Given this list of marker genes GRB2, FLT3LG, TLR9, FGF5, GAB2, IRS2 (insulin receptor substrate 2), FGFR2, FGF22, FGF4, PIK3R4, KRAS, FGF10, FGF23, FRS2, PTPN11, IRS1, PIK3CB, FGFR3, PIK3CA, PDE3B, FGF19, GAB1, NRAS, THEM4, PDPK1, KL, FGF3, FGFR1, SOS1, TRIB3, FGF8, FGF1, PIK3R1, FGF17, PIK3C3, FGFR4, FGF6, FGF9, FGF7, KLB, FGF18, FLT3, FGF2, FGF16, HRAS, AKT2, PIK3R2, FGF20, here is a description of the gene set: Human Gene Set: REACTOME_IRS_MEDIATED_SIGNALLING IRS-mediated signalling studied in species Homo sapiens